Given this list of marker genes NODAL, CD3G, MAMLD1, MED12, DVL3, IRF2BP2, RIPK1, SALL4, CACNA1C, PIGY, DISP1, LUZP1, COL7A1, DYNC2I1, DKC1, RRAS2, BRCA2, DYNC2H1, PRDM16, SMO, PIGV, COMT, LARGE1, PIGL, TGIF1, FKTN, RECQL4, RIPK4, HIRA, TNFRSF13B, TBC1D23, ATP2A2, CD81, FRAS1, WNT7A, NFIX, AR, MNX1, IL10RB, GLI3, TBX4, CCDC22, NBN, BCOR, ERCC4, FANCE (NCBI Gene Id 2178), RAD51, FANCA, UBE4B (NCBI Gene Id 10277), NFKB1, PGAP2, B3GLCT, ROR2, SKI, RERE, FLI1, TWIST2, PPP2R3C, HPS6, WNT3, MMP23B, IFT80, DPYS (dihydropyrimidinase), SEC24C, XRCC2, DPYSL5, POMT1 (protein O-mannosyltransferase 1), NDUFB11, LONP1, SNRPB, TNFSF12, SALL1, TCTN3, SETBP1, INTU, SPINT2, POMT2, THOC6, MKKS, GP1BB, CTNND1 (catenin delta 1), UBE2T, FREM2, TNFRSF13C, G6PC3, ROBO1, GAS1, DLL1, CHD7, RREB1, EHMT1, CDC45, CDH1, DDX3X, FOXH1, NAA10, DOCK8, CDH11, TBX1, RNU12, SYK, PALB2, C2CD3, BRIP1, USP9X, CHD4, PERCC1, FGFR2 (fibroblast growth factor receptor 2), COX7B, RFWD3, NCF2 (neutrophil cytosolic factor 2), CR2, DYNC2I2, MID1, FANCD2, HSPA9, DEF6, FERMT1, FREM1, TBX3, DCHS1 (dachsous cadherin-related 1), GLI2, EPCAM, HCCS, KCNAB2, CASZ1, CEP120, HSPG2, MAX, CAPN15, MAB21L1, SUZ12, DDX6, RSPO2, KAT6B, ICOS (NCBI Gene Id 29851), KYNU, UBR1, FOXC1, PKP1, FGF8, EXTL3, MMP1, TNRC6B, WBP4, GDF3, PGAP3, SCAF4, ADAM17, FANCB, PTDSS1, NSUN2, GPC4, FANCL, DACT1, JMJD1C, SEC61A1, CCNQ, AMER1, TP63, MEOX1, ABL1, LRPPRC, PORCN, ELANE, PIGW, ACADVL, MKS1, FOXF1, GABRD, HES7, PDPN, ZIC3, KMT2C, PIGN, CDK8, RAB34, BRCA1, SIX3, KDM6A, ATN1, MYCN, VPS35L, EMC1, CYBC1, PTCH1, MS4A1, SPEN, SHH, IKZF3, NXN, PIGO, FANCI, CDON (NCBI Gene Id 50937), PQBP1, PITX2, PRKCZ, FKRP, ELF4, FANCF, ESCO2, HOXD13, GDF6, RFX6, WASHC5, CD19, FANCM, WDR35, SLC25A24, ISL1, CRIPTO, NCF4, TGFB1, GPC3, EBF3, FUZ, RMRP, MAD2L2, STIL, NFKB2, GRIP1, FAT4, VANGL1 (NCBI Gene Id 81839), DDB1, UPB1, SLX4, RAD51C, SIN3A, KMT2D, FANCC, TBXT, CHRM3, ZIC2 (Zic family member 2), KIF7, ARVCF, UFD1, EGFR, TWIST1, NIPBL, POR, LIG4, FANCG, IL10RA, CD96, here is a description of the gene set: Abnormality of the anal canal. species: Homo sapiens Human Gene Set: HP_ABNORMALITY_OF_THE_ANUS Abnormality of the anus